The following is a description of a gene set: studied in species Homo sapiens Human Gene Set: GSE26928_NAIVE_VS_EFF_MEMORY_CD4_TCELL_UP from publication Chevalier N, Jarrossay D, Ho E, Avery DT, Ma CS, Yu D, Sallusto F, Tangye SG, Mackay CR (PMID 21471443) Genes up-regulated in comparison of naive CD4 T cells versus CD4 effector memory T cells., and this is the list of marker genes: THAP5, KLHL9, ZNF815P, GRK7 (G protein-coupled receptor kinase 7), RB1CC1, GXYLT1, FILNC1, SCML1, NDUFS4, ZSCAN18, TTC14, BAG4, DPEP2, METTL15, PHGDH, GTPBP10, UQCC1 (ubiquinol-cytochrome c reductase complex assembly factor 1), DOLK, POLL, ANP32A, PIK3R2, ZNF606, TMEM243, MSRB2, ERC1, H4C8, HSF2BP, SMAP2, TAS2R14, KRT27, GFOD3P, RCAN3, CNKSR2, PLLP, ESR1 (estrogen receptor 1), RALGPS2, APCS, SCAND2P, MTRFR, BDH1, GPATCH8, ZNF518B, LAS1L, FBXL17, H2AC6, ACSS2, TCEA3, GALNT14, CECR9, BCL2, SMO, ZNF37BP, MRPL19, KLHL22, LARP4B, MNS1 (meiosis specific nuclear structural 1), FILIP1L, SLC11A2, ZBTB7C, S1PR1, GPR157, SLC8B1, PRDM15, RAB33A, LGSN, STK25, PLXDC1, C8orf33, RBCK1, REEP6, FAM228B, LRP6, STYX, PRKCA, COQ8A, RHOBTB3, ZNF23, RRN3P1, PPCDC, RNF175 (NCBI Gene Id 285533), RMND5B, PCMTD2, RABEP1, FUBP1, MTAP, AZI2, SEPHS1, ANKRA2, ATF7IP2, ZC3H8, HERC2, TARBP1, C2orf74, POP5, TOPORS, TMEM132B, ALS2CL, RPP14, NCKIPSD, LIPT1, CERS6, SNHG3, HELQ, KBTBD3, NEXN, OCM2, TMEM134, ZNF705G, TTC28, MRPL51, MAVS, RNF157, TBP, CASP10, NTM, IPCEF1, TMEM204, ZC4H2, VPS35, EAF2, HCG4B, ZNF107, KLHL32, EIF1AX, MOSPD2, N4BP2L1, UQCC6, ZNF224, KLHL3, BCAS4, SFXN4, FBXW4, TAF1, ZIK1, DNAJC5, PIP4K2B, CDCA7L, MCM7, RBM48, YES1, KLHL11, CCDC65 (coiled-coil domain containing 65), COL18A1, COL4A4, CLK4, MARCHF3, CCDC28A, AIRIM, LIG1 (DNA ligase 1), ZNF33A, LRRN3, EXOSC7, FBXL4, BET1, FAM193B, HSD17B6, TENM1, KLF7, SGSM3, ICAM2, CDR1, WBP4, ASB13, NEK9, FAM241A, CFAP418, EPB41L4B, TTC32, ZFHX3, ZNF682, NSMCE4A, DDX18, ZNF512, ZC3H12B, EVL, STX16, ACBD4, SATB1, DSG3, CDKAL1 (CDK5 regulatory subunit associated protein 1 like 1), TGFBR1, ZC3H6, ARMCX1, EHBP1, MCFD2 (multiple coagulation factor deficiency 2, ER cargo receptor complex subunit), TFDP3, SCML2, MRPL24, PHYH, SUN1